The following is a description of a gene set: studied in species Homo sapiens Reactome Pathway: RMTs methylate histone arginines part of: Chromatin modifying enzymes Arginine methylation is a common post-translational modification; around 2% of arginine residues are methylated in rat liver nuclei. Arginine can be methylated in 3 different ways: monomethylarginine (MMA); NG,NG-asymmetric dimethylarginine (ADMA) and NG,N'G-symmetric dimethylarginine (SDMA). The formation of MMA, ADMA and SDMA in mammalian cells is carried out by members of a family of nine protein arginine methyltransferases (PRMTs) (Bedford & Clarke 2009). <br><br>Type I, II and III PRMTs generate MMA on one of the two terminal guanidino nitrogen atoms. Subsequent generation of asymmetric dimethylarginine (ADMA) is catalysed by the type I enzymes PRMT1, PRMT2, PRMT3, co-activator-associated arginine methyltransferase 1 (CARM1), PRMT6 and PRMT8. Production of symmetric dimethylarginine (SDMA) is catalysed by the type II enzymes PRMT5 and PRMT7. On certain substrates, PRMT7 also functions as a type III enzyme, generating MMA only. PRMT9 activity has not been characterized. No known enzyme is capable of both ADMA and SDMA modifications. Arginine methylation is regarded as highly stable; no arginine demethylases are known (Yang & Bedford 2013). <br><br>Most PRMTs methylate glycine- and arginine-rich (GAR) motifs in their substrates. CARM1 methylates a proline-, glycine- and methionine-rich (PGM) motif. PRMT5 can dimethylate arginine residues in GAR and PGM motifs. <br><br>PRMTs are widely expressed and are constitutively active as purified recombinant proteins. However, PRMT activity can be regulated through PTMs, association with regulatory proteins, subcellular compartmentalization and factors that affect enzyme-substrate interactions. The target sites of PRMTs are influenced by the presence of other PTMs on their substrates. The best characterized examples of this are for histones. Histone H3 lysine-19 acetylation (H3K18ac) primes the histone tail for asymmetric dimethylation at arginine-18 (H3R17me2a) by CARM1. H3 lysine-10 acetylation (H3K9ac) blocks arginine-9 symmetric dimethylation (H3R8me2s) by PRMT5. H4R3me2a catalyzed by PRMT1 favours subsequent acetylation of the histone H4 tail. At the same time histone H4 lysine-5 acetylation (H4K5ac) makes the H4R3 motif a better substrate for PRMT5 compared with PRMT1, thereby moving the balance from an activating ADMA mark to a suppressive SDMA mark at the H4R3 motif. Finally methylation of Histone H3 on arginine-3 (H3R2me2a) by PRMT6 blocks methylation of H3 lysine-5 by the MLL complex (H3K4me3), and vice versa, methylation of H3K4me3 prevents H3R2me2a methylation. N.B. Histone literature typically refers to coordinates of the protein after the initiating methionine has been removed., and this is the list of marker genes: SMARCB1, SMARCD2, H2AC20, ACTL6A, PRMT7, CCND1, ARID1A, H2AC4, RPS2, WDR77, JAK2, H2AC11, COPRS (NCBI Gene Id 95076), SMARCC1 (NCBI Gene Id 6599), WDR5, H2AC6, SMARCA2, H2AJ, SMARCA4, H2AC14, H3C15, H2AC7, SMARCD3, DNMT3A, H4C1, H3C1, SMARCC2, H2AZ2, ARID1B, H2AC12, H2AX, H2AC18, H2AC1 (NCBI Gene Id 221613), SMARCE1 (NCBI Gene Id 6605), CARM1, PRMT3, PBRM1, RBBP7, SMARCD1, ACTL6B, H2AB1, H2AC21, H2AC25, ARID2, PRMT5, PRMT6, PRMT1, CDK4